Given this list of marker genes CFL1, AURKB, SPAST, BNIP3, ADRB2, INSR, KATNB1, SEMA5A, SMCR8, TRPV4, EIF5A, STMN2, PPP1CA, EIF5A2, VIL1, CARMIL2, PDXP, IGF1R, CALCOCO2, PPP1R10, WNK1, TNF, EIF5AL1, CFL2, FYCO1, CARMIL1, NES, IRGM, UVRAG, SLN, DSTN, PLEK, CRACD, TOM1, JMJD4, F2RL1, WDR1, SETX, WASHC2C, ACTN2, here is a description of the gene set: Any process that activates or increases the frequency, rate or extent of protein complex disassembly, the disaggregation of a protein complex into its constituent components. Human Gene Set: GOBP_POSITIVE_REGULATION_OF_PROTEIN_CONTAINING_COMPLEX_DISASSEMBLY studied in species Homo sapiens